The following is a description of a gene set: Human Gene Set: GOBP_MEMBRANE_DEPOLARIZATION The process in which membrane potential decreases with respect to its steady-state potential, usually from negative potential to a more positive potential. For example, the initial depolarization during the rising phase of an action potential is in the direction from the negative steady-state resting potential towards the positive membrane potential that will be the peak of the action potential. species: Homo sapiens, and this is the list of marker genes: FZD9, ADORA2A, KCNQ3, P2RX7, DCN, ABCD1, CLCN2, ATP1A2, CHRNA3, SLC6A4, CACNA1G, FHL1, HCN2, CREB1, SCN1B, HSH2D, PARP1, CHRNA6, KCNJ2, SRC, TBX5, IFI6, CHRNB4, GPD1L, GCLC, B2M, CDKN2A, SCN1A, ATP5IF1 (NCBI Gene Id 93974), CACNA1C, KCNH2, MIR26A1, CACNG2, PHOX2B, SLC8A1, ASIC3, SLMAP, RACK1, YWHAH, P2RX4, COL6A1 (NCBI Gene Id 1291), CHRNA2, SCN3A, HCN4, TSPO, NEDD4L, ANK2, SCN2B, PPIF, PPP2R3C, TRPM4, KDR, CHRNB1, ANK3, CHRNA1, BOK, HCN3, SCN11A, PTPN3, KMT2A, ADCY10, ABL1, CHRNB2 (NCBI Gene Id 1141), CNGB1, CACNB2, CAMK2D, MIR208A (NCBI Gene Id 406990), NPFF, LRRK2, SMAD7, EDN1, BCL2, CHRNA5, SCN5A, SCN3B, MLLT11, SCN4B, CHRNG, CACNA2D1, MYOC, BEST2, CHRNA4, SCN10A, CHRNB3, GOT1, CACNA1D, CHRNA10, CAV1 (NCBI Gene Id 857), MIR1-1, RANGRF, GCLM, ALB, CHRND, CAV3, PARK7, CHRNE, CHRNA9 (cholinergic receptor nicotinic alpha 9 subunit), GJA5, HCN1, NTSR1